The following is a description of a gene set: studied in species Mus musculus Cytokines mediate cell-cell communication in the immune system and represent important therapeutic targets. A myriad of studies have highlighted their central role in immune function, yet we lack a global view of the cellular responses of each immune cell type to each cytokine. To address this gap, the authors created the Immune Dictionary, a compendium of single-cell transcriptomic profiles of more than 17 immune cell types in response to each of 86 cytokines (>1,400 cytokine-cell type combinations) in mouse lymph nodes in vivo. A cytokine-centric view of the dictionary revealed that most cytokines induce highly cell-type-specific responses. For example, the inflammatory cytokine interleukin-1β induces distinct gene programmes in almost every cell type. A cell-type-centric view of the dictionary identified more than 66 cytokine-driven cellular polarization states across immune cell types, including previously uncharacterized states such as an interleukin-18-induced polyfunctional natural killer cell state. from publication Cui A, Huang T, Li S, Ma A, Pérez JL, Sander C, Keskin DB, Wu CJ, Fraenkel E, Hacohen N (PMID 38057668) Genes negatively differentially expressed in cell type: CD8+ T cell upon treatment with cytokine: IL-17C in mouse lymph nodes in vivo. Mouse Gene Set: CUI_T_CELL_CD8_IL17C_RESPONSE_DN, and this is the list of marker genes: Hspa1a, Hspa1b, Tsc22d3, Klf6, Fos